The following is a description of a gene set: Mouse Gene Set: XIE_TRASTUZUMAB_CARDIOTOXICITY_MMU_MIR_329_3P_GENES studied in species Mus musculus from publication Xie S, Zhou N, Su N, Xiao Z, Wei S, Yang Y, Liu J, Li W, Zhang B (PMID 38577019) Abstract: Trastuzumab-induced cardiotoxicity (TIC) is a common and serious disease with abnormal cardiac function. Accumulating evidence has indicated certain non-coding RNAs (ncRNAs), functioning as competing endogenous RNAs (ceRNAs), impacting the progression of cardiovascular diseases. Nonetheless, the specific involvement of ncRNA-mediated ceRNA regulatory mechanisms in TIC remains elusive. The present research aims to comprehensively investigate changes in the expressions of all ncRNA using whole-transcriptome RNA sequencing. The sequencing analysis unveiled significant dysregulation, identifying a total of 43 circular RNAs (circRNAs), 270 long noncoding RNAs (lncRNAs), 12 microRNAs (miRNAs), and 4131 mRNAs in trastuzumab-treated mouse hearts. Subsequently, circRNA-based ceRNA networks consisting of 82 nodes and 91 edges, as well as lncRNA-based ceRNA networks comprising 111 nodes and 112 edges, were constructed. Using the CytoNCA plugin, pivotal genes - miR-31-5p and miR-644-5p - were identified within these networks, exhibiting potential relevance in TIC treatment. Additionally, KEGG and GO analyses were conducted to explore the functional pathways associated with the genes within the ceRNA networks. The outcomes of the predicted ceRNAs and bioinformatics analyses elucidated the plausible involvement of ncRNAs in TIC pathogenesis. This insight contributes to a better understanding of underlying mechanisms and aids in identifying promising targets for effective prevention and treatment strategies., and this is the list of marker genes: Adam1a, Bcl2l1, Cops7b, Sin3a, Fbf1, Rgs6, Rab3d, D630045J12Rik, Adam17, Cd59a, Pik3cd, Xpnpep3, Arid1b, Csmd2, Camta1, Exog, Hcn1, Rnf114, Gcnt1, Btbd3, Cadm1, Cspg4b, Wbp1l, Ss18, Usf3, Dlgap4, Dido1, Atosb (atos homolog B), Rai14, Nap1l4, Pappa2, Mcf2l, Gsk3b, Nrp2, Mfsd4b4, Celf1, Kcnj4